Given this list of marker genes NPFFR2, QRFP, HCRTR1, NPFFR1, HCRTR2, QRFPR, HCRT, NPFF, here is a description of the gene set: The orphan G protein-coupled receptors mentioned here regulate sleep and appetite. Reactome Pathway: Orexin and neuropeptides FF and QRFP bind to their respective receptors species: Homo sapiens part of: Peptide ligand-binding receptors